The following is a description of a gene set: The chemical reactions and pathways resulting in the breakdown of a triglyceride, any triester of glycerol. Human Gene Set: GOBP_TRIGLYCERIDE_CATABOLIC_PROCESS species: Homo sapiens, and this is the list of marker genes: PNPLA4 (NCBI Gene Id 8228), PNLIP, APOC1, PLB1, PLIN5, AADAC, APOA5, DAGLB, PNLIPRP2, PNPLA2, GPLD1, ABHD5, APOC2 (NCBI Gene Id 344), APOA4, MGLL (NCBI Gene Id 152009), SORL1, PIK3CG, PNPLA1, LIPC, LIPE, DDHD2, CPS1, FUT1, PNPLA3, LPL, GPIHBP1, APOC3, LIPG, PNLIPRP3, PNLIPRP1, APOB, PNPLA5